Given this list of marker genes CAMSAP2, TFPI2, XRN1, RPS6KA3, RAB33B, LCOR, OTUD3, PTPRJ, NUP58, MTM1, C17orf75, NCAPG2, C2CD5, RIMKLB, BCL11A, SLC35A3, GCLC, PTPRA, PDE4D, ARID1A, REEP1, ANOS1, DOCK10, HMGB3, RAI14, DHX36, SLC12A2, CLCN3, PHACTR2, METTL15, CPEB2, CPNE8, HMGB1, SETD5, ZNF281 (NCBI Gene Id 23528), CCND3, FBN1, TMEM236, ALDH1A3, PROX1, PRPF39, NT5C2, SSMEM1, PPIE, MAGEA10 (NCBI Gene Id 4109), RAPGEF6, IKZF5, ABL2, FAM227A, TRA2B, CCDC102A, NAMPT, RASGRP1, LDHD, LATS1, UCHL5, TRIQK, SPG11, CASK, GAPVD1, ZFP14, SPTY2D1, ENTPD7, CDC73, DCK, RRM2, SCAP, RASSF8, SLC27A3, ZIC3, COL4A1, HOXA1, SAFB, MS4A15, HYCC2, PEX14, PRR11, KLHL5, ZNF367, SPTLC2, SS18, KRAS, RAB27A, SRSF10, ABTB2, EIF5A2, SCAMP1, LARP6, GSE1, SNX10, APPL2, MX1, MAPK10, CTNNB1, UBE2D2, IGF2R, MPP7 (NCBI Gene Id 143098), PNRC2, CSE1L, RBM27, TMEM230, PTGES3, AAK1, CHMP4B, ELOVL6, MEGF11, TMEM26, TFDP1, PTPRB, ANKRD10, ADAMTS5, NT5DC1, RCHY1, MSX1, RCBTB1, MARK1, GPR82 (NCBI Gene Id 27197), COPS5, MEF2C, PDS5B, KIF13A, RAB5A, TBPL1, STAU2, GPR180, NCSTN, TRIAP1, HECTD3, A4GNT, MAPK8IP1, PHF6, SHANK2, COL5A2, GPC6, PRDM12, HTATIP2, RSBN1L, CNTN4, THAP5, SALL1, PPP5C, MAPK8, RRAS2, JMY, PLEKHM3, STEAP2, MINDY2, PLPPR5, TNFRSF19, FUNDC1, FNDC3B (fibronectin type III domain containing 3B), TMOD2, NIF3L1, LSM11, VDAC1, ROCK2, CHRNA5, NR4A2, TAF1, VKORC1L1, CNOT2, UBE2B, SV2B, BZW1, IFIT1, ZNF780B, KHDRBS2, GRIK2, INPP5B, GK5, ITGB8, QKI, CACNB4, BMPR2, ST6GALNAC3 (ST6 N-acetylgalactosaminide alpha-2,6-sialyltransferase 3), FGF9, WIPF1, HOOK3, TNFAIP1, SFRP2, LCLAT1, YBX1, CNST, ITM2B, CYP20A1 (NCBI Gene Id 57404), NTN4, KCNN4, NEK7, MOB1B, PPP1R8, ANKRD44, NF1, GFPT1, PLAG1, PCF11, RPS6KB1, ABI1, PPP1R1B, ARSJ, SH3BP5, GJC1, STON2, CTTNBP2, TMEM59, MIGA1, TRIM33 (NCBI Gene Id 80027), PRICKLE2, TSPAN13, RNASE4, SSR1, ZBTB18, INO80D, PDE7A, TGFBR3, GAREM1, ETV1, KLHL24, GLCCI1, DLGAP1, SPATA13, CTTNBP2NL, ONECUT2, OCRL, SEPTIN7, DAB2IP, TMCO3, EEA1, CAMKK1, ARID4B (AT-rich interaction domain 4B), CCSER1, CAV2, METAP1, HCN1, MAMLD1, CTSS, PRSS12, RASAL2, FCHO2, VGLL4, ARHGAP12, ZNF737, INTS12, LSM14A, ZNF569, MTCL1, TAOK1, RAPH1, NPAS2, ABI3BP, PPP4R3A, LHX6, HAUS2, HSPA13, PGM2L1, TUBB2B, PHF20, MED13, RNF138, LRP1B, RTF1, SETMAR, COL11A1 (collagen type XI alpha 1 chain), BMP7 (NCBI Gene Id 655), SPP2, CTDSPL2, SCG2, SGIP1, TBC1D19, NECAB1, GRIA4, RNLS, SPTBN1, PPFIA2, GPHN, ZNRF2, IDS, PRR15L, FOXO1, CREB1, JAZF1 (NCBI Gene Id 94314), CNR1, ADAMTS3, ZNF681, CAPZA2, MAPK1, LIPF, NTNG1, STUB1 (STIP1 homology and U-box containing protein 1), LEMD3, SCAF8, TMEM221, DYNC1H1, ERLIN1, FAM218A, MSI2, TLE4, ARIH1, MPHOSPH6, SLC23A2, EIF4E, ARFGEF1, PTPRD, NEGR1, RPGR, ELOVL5, NLK, PTPN13, ATAD2B, SHISA6, ANKRD22, ABHD18, ZNF780A, SFT2D1, STK3, EMP2 (NCBI Gene Id 2013), MRPL51, ACSL6, ACP6, ZNF546, ENSG00000286190, NAA16, ATP1A2, PROKR2, OPA3, HIVEP2, EIF4G2 (eukaryotic translation initiation factor 4 gamma 2), TAX1BP1, SCN8A, DCAF7, PEG3, SGK1 (serum/glucocorticoid regulated kinase 1), LSMEM2, ITSN1, PTPN9, RECK, SCAI, ELF3, GCLM, CEP20, KAT2B, DNAJC6, MEGF10, MAN2A1 (mannosidase alpha class 2A member 1), HMMR (hyaluronan mediated motility receptor), TLCD4, PPP6R3, EDDM3A, IPO4, DOP1B, MRPL57, PTCH1, TBL1XR1, NYAP2, SEC24A, MYOCD, SLC2A13, KAT6A, HSPD1, SIAH1, PSME4, SLC7A11, CHUK, TGFB2, CYP27C1, VASH2, CUL2, APC, CCSER2, CCDC186, ASB1, KLF4, ASPN, here is a description of the gene set: Human Gene Set: MIR6504_3P Genes predicted to be targets of miRBase v22 microRNA hsa-miR-6504-3p in miRDB v6.0 with MirTarget v4 prediction scores > 80 (high confidence targets). from publication Chen Y, Wang X (PMID 31504780) studied in species Homo sapiens